Given this list of marker genes Nkx3-1, Rxra, Wnt5a, Ube3a, Hells, Fkbp4, Wdr77, Plag1, Frs2, Mmp2, Hoxa13, Acvr1, Pax2, Nog, Pax8, Acd (adrenocortical dysplasia), Amh, Bmp7, Serpinf1, Lhx1, Rara, Hoxd13, Igf1, Gata2 (NCBI Gene Id 14461), Notch1, Serpinb5, Esr1, Fem1b, Esr2, Sfrp1, Pbx1, Stk11, Hoxa9, Pten, Hoxb13, Ephb3, Ctnnb1, Hoxa11, Apc, Ephb2, Ptch1, Prlr (prolactin receptor), Eaf2, Crkl, Foxa1, Foxb1, Shh, Igf1r, Gli2, Sox9, Cdkn1b, Ar, Fgfr2, Gli1, Cyp19a1 (cytochrome P450, family 19, subfamily a, polypeptide 1), Fgf10, Cd44, Osr1, Tnc, Plaur, Cyp7b1, Stat5a, Bmp4, Trp63, Hoxa10, Osr2 (NCBI Gene Id 93693), Psap, Id4, Wnt11 (NCBI Gene Id 22411), Sulf1, Ahr, Smarcc1, Psapl1, Gli3, Rarg, Rln1, here is a description of the gene set: Mouse Gene Set: GOBP_UROGENITAL_SYSTEM_DEVELOPMENT species: Mus musculus The process whose specific outcome is the progression of the urogenital system over time, from its formation to the mature structure.